The following is a description of a gene set: Human Gene Set: GOBP_APOPTOTIC_CELL_CLEARANCE The recognition and removal of an apoptotic cell by a neighboring cell or by a phagocyte. species: Homo sapiens, and this is the list of marker genes: SPG11, FCN2, AXL, ABCA7, TIMD4, ITGAV, GAS6, MERTK, CCL2, XKR8, C4B, MFGE8, TYROBP, XKR7, PEAR1, THBS1, C2, TREM2, TREX1, FCN1, CD300LF, FCN3, JMJD6, CCR2, ANXA1, HMGB1, RARA, RAC1, C4A, ITGB3, TYRO3, XKR4, NR1H3, CD36, TGM2, XKR6, ADGRB1, ALOX15, LRP1, MEGF10, C3 (complement component 3), SCARB1, MARCO, BECN1